Given this list of marker genes IDS, RABL3, POLG, HNRNPK, RAD21, PALLD, FLNA, MT-ND1, CDKN2A, BRCA1, MT-CO3, TP53, MT-ND5, TYMP (thymidine phosphorylase), SMAD4, KRAS, SGO1, MT-CO2, LIG3, MT-ND6, MT-TQ, MT-TH, MYH11, MT-TF, ACTG2, SMO, ERBB3, MT-TW, MT-ND4, TWNK, MT-TL1, PALB2, BRCA2 (BRCA2 DNA repair associated), MT-TS2, MT-CO1, here is a description of the gene set: studied in species Homo sapiens Intestinal pseudo-obstruction Human Gene Set: HP_INTESTINAL_PSEUDO_OBSTRUCTION A functional rather than mechanical obstruction of the intestines, associated with manifestations that resemble those caused by an intestinal obstruction, including distension, abdominal pain, nausea, vomiting, constipation or diarrhea, in an individual in whom a mechanical blockage has been excluded.